The following is a description of a gene set: Interacting selectively and non-covalently and stoichiometrically with neuropeptides, peptides with direct synaptic effects (peptide neurotransmitters) or indirect modulatory effects on the nervous system (peptide neuromodulators). species: Mus musculus Mouse Gene Set: GOMF_NEUROPEPTIDE_BINDING, and this is the list of marker genes: Mc3r, Galr2, Mrgpra3 (MAS-related GPR, member A3), Sstr4, Mrgprb5, Npy5r, Npy1r, Sstr3, Sstr5, Mrgprx2, Oprm1, Gpr171, Cmklr2 (chemerin chemokine-like receptor 2), Sstr1, Nmur1, Oprl1, Mrgprb1, Kiss1r, Sstr2, Npy4r, Galr1, Prlhr, Oprk1, Gpr149, Mrgprb2, Ptgdr2, Oprd1, Mrgprb4, Grpr, Npbwr1, Sorl1, Mchr1, Adcyap1r1, Npy6r, Mrgprb8, Gpr37, Nmur2, Mrgprb3, Mc4r